The following is a description of a gene set: The disaggregation of a cell-cell junction into its constituent components. Human Gene Set: GOBP_CELL_CELL_JUNCTION_DISASSEMBLY studied in species Homo sapiens, and this is the list of marker genes: TGFBR1, FER, TGFB3, IL1B, MYLK3, ABCC8, SNAI2